Given this list of marker genes Sae1, Ube2i, Sumo1, Uba2, Rwdd2b, here is a description of the gene set: SUMO is transferred from E1 to E2 (UBE2I, UBC9) studied in species Mus musculus Mouse Gene Set: REACTOME_SUMO_IS_TRANSFERRED_FROM_E1_TO_E2_UBE2I_UBC9